Given this list of marker genes UBC, CCNI (NCBI Gene Id 10983), MTBP, DPM1, RHBDF1, KCTD10, MRPL13, BRI3 (brain protein I3), STARD5, SMG6, LRP6, MTCO3P31 (NCBI Gene Id 107075186), EFCAB7, HDAC7, NCAPD2, LRRC23, BTG3-AS1, PSAT1P2, RNF148, AP1G1, HOXA3, CIC, UBE3B, TMEM248, TECPR1, COQ10B, MRPL51, KAT5 (NCBI Gene Id 10524), NR2F1, ITGB3BP, MIR5188, CHD2, RAB11A, MOCS3, MTND3P20, ZCCHC2, TMEM125, ATP1A3, VDR, RPL17-C18orf32, PPIC-AS1, RPL17, here is a description of the gene set: species: Homo sapiens from publication Yevshin I, Sharipov R, Kolmykov S, Kondrakhin Y, Kolpakov F (PMID 30445619) Human Gene Set: CDX1_TARGET_GENES Genes containing one or more binding sites for (CDX1) in their promoter regions (TSS -1000,+100 bp) as identified by GTRD version 20.06 ChIP-seq harmonization.